Given this list of marker genes Fgf13, Kcnq1, Grp, Fgf12, Tmem168, Scn1b, Slmap, here is a description of the gene set: Any process that modulates the frequency, rate or extent of voltage-gated sodium channel activity. species: Mus musculus Mouse Gene Set: GOBP_REGULATION_OF_VOLTAGE_GATED_SODIUM_CHANNEL_ACTIVITY